Given this list of marker genes Ctnnbip1, Dcstamp, Cd74, Cd4, Jun, Il34, Zfp36l1, Fes, Acin1, Csf1, here is a description of the gene set: Any process that activates or increases the frequency, rate or extent of monocyte differentiation. species: Mus musculus Mouse Gene Set: GOBP_POSITIVE_REGULATION_OF_MONOCYTE_DIFFERENTIATION